The following is a description of a gene set: Mouse Gene Set: MIR_33_3P species: Mus musculus from publication Chen Y, Wang X (PMID 31504780) Genes predicted to be targets of miRBase v22 microRNA mmu_miR_33_3p in miRDB v6.0 with MirTarget v4 prediction scores > 80 (high confidence targets)., and this is the list of marker genes: Kcnq5, Top2b, Rbm25 (NCBI Gene Id 70221), Uox, S1pr1, Gm11992, Cadm2, Tex30, Nrp2, Rab10, Frmpd4, Blm, Vps13a, Mmp27, Ugt1a10, Fbxo48, Rbsn, Lin54, Adam9, Elovl5, Adipor2, Dpf2, Clock, 4930486L24Rik, Ints9, Frs2, Ppp3ca, Fut9, Sf3b1, Cry1, Ugt1a6a, Cited2, Pclaf, Npas3, Rapgef4, Stx12, Med13, Alb, Gna13 (guanine nucleotide binding protein, alpha 13), Hal, Senp7, Glis1, Ankrd22, Mrpl39, Lrch2, Bcl2, Fgf12, Mrpl36, Hectd1, Rbm34, Patj, Eml5, Napepld, Col4a5, Smim17, Igsf10, Zfp442, Ube2d3 (NCBI Gene Id 99495), 4930426D05Rik, Cav2 (caveolin 2), Glcci1, Prl8a8, Cpd (carboxypeptidase D), Wac, Cfhr4, Dnaaf2, Cyfip1, Ankib1, Tmtc2, Hnrnpu, Rcbtb2, Chchd5, Zfp229, Zfp580, Dnajc21, Ubqln2, Abhd13, Rbm46, Ugt1a2, Triobp, Cpq, Rell1, Tcaf2, Ugt1a7c, Spred1 (sprouty protein with EVH-1 domain 1, related sequence), Slc1a3, Mettl25, Orc3, Baz1b, Otc, Dusp19, Crispld1, Scaf8, Map3k2, Sema5a, Tpgs2, Zfp750, Tm9sf3, Plpp3, Plekhb2, Tmem47, Ccnc, Zfp472, Zbtb24, Rttn, Uqcc1, Prkce, Sema3d, Ogn, Uck1, Pex2, Fmr1, Hephl1 (NCBI Gene Id 244698), Efcab14, Fgf14, Phtf2, Plekha1, Rag2, Lrrtm2, Rsbn1l, Ep300, Ide, Snai2, Spin1, Rsbn1, Atxn3, Elp4, Afg2a, Zc3h6, Egf, Pcgf6, Ehmt1, Gria3, Kcnd2, Kidins220, Nemf, Spag11a, Pcsk2, Tdg, Galnt13, Rpf1, Nfkbiz, Usp45, Elf1, Uqcrfs1, Phf14, C1qtnf1, Etnk1, Phf6, Sfrp2 (NCBI Gene Id 99743), Ahr, Kmt5b, Zfp800, Zfp507, Igtp, Lsm14a, Pcdh17, Slc38a1, Zfp712, Nr4a3, Zfp148, Ranbp6, Apex1, Qki, Pde7b, Trmt1l, Elavl1, Cct7, Tle4, Epha5, Atp8a1, Rigi, Gria2, Baz1a, Eri1, Slit2, Cpt1a, Zeb2, Esp1, Zfp280b, Bag5, Serinc1, Slc4a10 (NCBI Gene Id 94229), Fgg, Zfp937 (zinc finger protein 937), Fat1, Usp37, Ostf1, Amotl2, Prex2, Hnrnpll, AU018091, Sacm1l, Nufip2, Lmo7, Klhl31, Csnk1a1, Larp4, Stx1a, Erh, Il1rapl2, Lrrn4cl, Lats2, Ifit2, Ugt1a9 (NCBI Gene Id 394434), Usp18, Aggf1, Rasal2, Fcho2, Lmo4, Pnp2, Adam22, C1d, Gfra3, Ywhab, Usp38, Ewsr1, Magt1, Itga6, Resf1, Tet2, Clint1, Ctnnd1, Cfhr2, Kras, Ube2n, Il11, Ugt1a5 (NCBI Gene Id 394433), Btbd8, Ptprk, Ptafr, Col25a1, Cldnd1, Mcm8, Lca5, Tigd5, Mmd, Far1, Fhip1a, Cd247 (NCBI Gene Id 98717), Gng2, Crebrf, Parp8, Rsf1, Clk4, Gucy1a1, Sod2, Cacnb4, Zfp260, Dhx15, Erv3, Prr5l, Ccdc88a, Steap2, Tmf1, Fgd4, Dnm3, Hey2, Rabgap1l, Sycp3, Cpeb2, Vti1a, Foxn2, Cfh, Bcl6, Slc25a16, Gpr22, Gja1, Trps1, Prdx3, Pla2g4a, Paxbp1, Dlgap5, Vldlr, Creb1, Dnajc3, Lhx9, Grb10, Ugt1a1, Ddo (NCBI Gene Id 78278), Mgst1, Tfap2a, Uba2, Qtrt2, Bcor, Orc6, Zfp846, Slc10a1, Gm5431, Smim13, Cnot7, Kcnh3, Rmdn1, Scai, Cep170, Rer1, Gas2l3, Reep3, Casd1, Gnpda2, Togaram1, Kdm7a, Pbdc1, Lce1g, Usp19, Accs, Rfx7, Phyhipl, Zfp955b, Gucy1a2, Gigyf1, Slc8a1, Pde7a